The following is a description of a gene set: Any process in which an organism or cell protects itself from ultraviolet radiation (UV), which may also result in resistance to repeated exposure to UV. species: Homo sapiens Human Gene Set: GOBP_UV_PROTECTION, and this is the list of marker genes: XPA, ERCC1 (NCBI Gene Id 2067), MC1R, GPX1, CAT, SDF4, SCARA3, FEN1, MFAP4, ERCC2, ERCC4, ERCC3